Given this list of marker genes Ehd2, Pacsin1, Atp10a, Asap1, Sh3gl2, Fnbp1l, Snx9, Bin3, Bin2 (bridging integrator 2), Pacsin2, Snx18, Cavin2, Dnm2, Snx33, Whamm, Sh3glb1, Wasl, Micall1, Pacsin3, here is a description of the gene set: species: Mus musculus Mouse Gene Set: GOBP_PLASMA_MEMBRANE_TUBULATION A membrane tubulation process occurring in a plasma membrane.